The following is a description of a gene set: The developmental process that results in the deposition of coloring matter in an organism, tissue or cell. Human Gene Set: GOBP_DEVELOPMENTAL_PIGMENTATION studied in species Homo sapiens, and this is the list of marker genes: BCL2, SLC45A2, SOX10, USP13, AP1M1, MREG (NCBI Gene Id 55686), EDNRA, BCL2L11, EDNRB, TYRP1, OCA2, TPCN2, SPNS2, BLOC1S5, BLOC1S6, ADAMTS20, KITLG, CITED1, VPS33A, CD63, GPR143, ATP6AP2, MEF2C, ADAMTSL4, RAB32, LRMDA, GNA11, MITF, HPS4, ANKRD27, EDN3, GLI3, RAB38, RAB27A (NCBI Gene Id 5873), DCT, OR51E2, AP3D1, IHH, HPS5, ADAMTS9, ENPP1, SOD2, TYR, BAX, BLOC1S3, AP1G1, KIT, ZEB2